Given this list of marker genes Abcb7, Asic3, Slc46a1, Flvcr2, Lcn2, Flvcr1, Hpx, Slc48a1, Slco2b1, Abcc5, Pgrmc2, Slc22a17, Abcb6, here is a description of the gene set: Mouse Gene Set: GOBP_IRON_COORDINATION_ENTITY_TRANSPORT The directed movement of an iron coordination entity into, out of or within a cell, or between cells, by means of some agent such as a transporter or pore. studied in species Mus musculus